Given this list of marker genes Hmox2, Nsun7, H2bc24, H2bc23, Kdelr2, Fam81a, Wfdc18, Thbs2, Elavl2, Map1lc3b, Edem1, Ido2, Lhx8, Nudt2, Sp4, Neo1, Lman2l, Ngef, Hacd2, St6gal1, Eif1ad8, Ythdf3 (YTH N6-methyladenosine RNA binding protein 3), Poln, Btaf1, Dennd1b, Fhl2, Calca, Cysltr2, Krtap19-3, Kit, here is a description of the gene set: species: Mus musculus from publication Chen Y, Wang X (PMID 31504780) Mouse Gene Set: MIR_6381 Genes predicted to be targets of miRBase v22 microRNA mmu_miR_6381 in miRDB v6.0 with MirTarget v4 prediction scores > 80 (high confidence targets).